The following is a description of a gene set: Conditional IRF8 KO mice (mice with a conditional allele of Irf8 crossed with CD19-Cre mice) showed increased numbers of both Gene expression data spleen marginal zone (MZ) and Gene expression data spleen follicular (FO) B cells compared to control mice. To evaluate gene expression patterns that distinguished FO or MZ B cells derived from conditional KO and control mice, we used Affymetrix GeneChip® Mouse gene 1.0 ST Array. studied in species Homo sapiens from publication Feng J, Wang H, Shin DM, Masiuk M, Qi CF, Morse HC 3rd (PMID 21178004) Human Gene Set: GSE24972_MARGINAL_ZONE_BCELL_VS_FOLLICULAR_BCELL_IRF8_KO_UP Genes up-regulated in spleen B lymphocytes with IRF8 knockout: marginal zone versus follicular., and this is the list of marker genes: HPRT1, ACAD10, SEC14L1, KIAA1217, GGCX, ANAPC16, PDXDC1, BOK, RTCB, DEF8, PROCA1, IDNK, MAP4K2, HDLBP, ST6GALNAC3, TCHH, PPM1L, KANSL2, ZC3H15, RBAK, UBLCP1, LGALSL, RIPOR1 (RHO family interacting cell polarization regulator 1), LDLRAD3, FXYD2, LTBR, RMND1, HDDC3, SLC7A11, SCAMP3, EZR, ECE1, TMEM37, CDH2, FAM32A, MAPK8IP3, CSMD1, ASCC1, KCNMB4, SPATA13, ID1, CDR2L, IPO11, IL22, ADGRL4, PTPRK, ADAMTSL4, HS3ST1, PIGB, EIF2B5, CACNA1D, F2R, METTL26, FGG, PCOLCE, PDLIM7, UBE2B, AK1, NFIL3, HLA-DMA, FHOD3, FAM83D, ZNF569 (zinc finger protein 569), C5orf24, IRF1, ICOS, SOCS2, CTSE, COL4A2, UBXN2A, CAD, CD74, GPX8, ASB3, SYNE2, TMEM63A, PTPRG, APOBR, SLC28A3, MTHFD1L, CCPG1, RUVBL2, CCDC124, METTL13, PRC1, FST, CSK, USP2, RTEL1, TDRP, GMFG, PBXIP1, DYRK3 (NCBI Gene Id 8444), PLK3 (NCBI Gene Id 1263), CLEC4E, PXDN, HR, CLK3, MIF, LMNB2, SUMF2, YPEL2, SLC6A12, TSC2, AP1S2, FTMT, HNMT, GREM1, KNTC1, FDXR, RAB5IF, HLA-A (major histocompatibility complex, class I, A), TNRC6B, IL18BP, LRRC8C, TF, SQSTM1, EXOC3, PRKCSH, UBE2V1, SPOCK2, NAA16, LUZP1, HNRNPA0, FRMD5, RAB24, PRR32, APP, CPE, SERF2, KLF11, DDHD1, ARHGAP42, SLC46A3, GRK2, FAM171B, NUAK1, RGS13, DDX24, RXRA, NAT8L, ANLN, AMOTL2 (angiomotin like 2), EVA1B, MYO1D, TRIP10, TPH1, CCND1, C9orf78, DZIP1, TCERG1, COL4A5, PRMT8, RBM28, RPS6KB1, PDXP, TIMP1, IPMK, BUD31, GATA4, NGDN, GTF2H2, UHRF1, HMMR, HLA-DQA1, GINS1, LIMK2, NEXMIF, TAFA5, ANKRD37, ANKRD22, PAN3, AIF1, SLC28A2, CREBRF, MXD1 (MAX dimerization protein 1), MDM2, PTCHD1, C11orf86, KDSR, HLA-DMB, FOLR2, PAPSS2 (NCBI Gene Id 9060), AXL, ENSG00000285566, SLC9A9, ADCK5, GALNTL5, EMILIN2, CBR3, ZMYND8, NLRP3, ARG1, UBE2C, HOXA11, YPEL5, OTUD7A, JTB, TM4SF1, PLEKHG3